The following is a description of a gene set: Human Gene Set: GOBP_EMBRYONIC_BODY_MORPHOGENESIS The process in which the anatomical structures of the embryonic soma are generated and organized. studied in species Homo sapiens, and this is the list of marker genes: OFD1, CDON, MAB21L2, NCKAP1, ZNF281, IFT122, FUZ, GREM2